The following is a description of a gene set: Genes predicted to be targets of miRBase v22 microRNA hsa-miR-542-3p in miRDB v6.0 with MirTarget v4 prediction scores > 80 (high confidence targets). from publication Chen Y, Wang X (PMID 31504780) studied in species Homo sapiens Human Gene Set: MIR542_3P, and this is the list of marker genes: C6orf47, SYT17 (synaptotagmin 17), ANOS1, IL33, WDR33, RBM15B, ZXDA, PDIA6, TBL1XR1, RTRAF, MMAB, ZIC1, PUM2, SEPTIN2, FYCO1, FIG4, TMEM65, SPRED1, PFKM, GPRIN1, PSME3, GDNF, JADE2, LYSMD4, ANGPT2, CCDC71L, LPP, USP25, MUC7, POU2AF1, NKX3-1, ITGB1BP1, SLC12A2, CA10 (NCBI Gene Id 769), ALCAM, FLRT3, FEM1C, EMSY, ZFHX3, CTLA4, HAPLN4, COA7, GFRA1 (GDNF family receptor alpha 1), PHYHIP, SUN2, UBE3C, PLEKHA6, VPS26A, APLF, BIRC5, FUT9, DDX25, SNTB2, RPS6KB1, TRNT1, AP3D1, AHR, ZNF618, AMMECR1, PRIM2, B3GNT5, OSGIN2, SH3KBP1, CILP, PIK3R1, ABR, RNF114, LRRC2, ATP8A2 (NCBI Gene Id 51761), HIPK3, ZFHX4, YPEL5, ZFP28, FBN1, SERPINB8, ITPRIP, TCF12, HS2ST1, NXPH2, SUCLG2, AFAP1L1, EBP, PARP12, GBE1, CLBA1, UQCR11, KPNA3, RBPMS, TPGS2, GSTZ1, ZFR2, FHOD3, ARK2N, RAB44, PAK3, MPRIP, PAPSS2, SLC33A1, BRK1, DCUN1D1, UBE2E1, TNFSF14, DDI2, PLEKHM3, MINPP1, ANKRD10, PWP1, MYH9, FBXO6, BNIP2, PRDM16, TKTL1, SNU13, CDC5L, DCBLD2, COLGALT2, ELAPOR2, ELAVL2, RSBN1, PTGS2 (prostaglandin-endoperoxide synthase 2), PELI2, RPS6KA4, PLA2R1, VAPB, CTCF, F11, ARMC8, TSHZ2, EVC, SMIM14, TSC22D1, STC1, FKBP1B, MYLIP, KMT2E, BTAF1, CCNT1, SHISA7, YME1L1